The following is a description of a gene set: Catalysis of the reaction: ATP + 1D-myo-inositol hexakisphosphate = ADP + diphospho-1D-myo-inositol-pentakisphosphate. The isomeric configuration of diphospho-1D-myo-inositol-pentakisphosphate (PP-IP5) is unknown. Mouse Gene Set: GOMF_INOSITOL_HEXAKISPHOSPHATE_KINASE_ACTIVITY studied in species Mus musculus, and this is the list of marker genes: Ppip5k1, Ip6k2, Ip6k3, Ip6k1, Itpkb, Itpkc, Ppip5k2, Itpka